The following is a description of a gene set: Genes up-regulated in H1299 cells (lung cancer) by expression of SMARCA4 off a plasmid vector. studied in species Homo sapiens from publication Medina PP, Carretero J, Ballestar E, Angulo B, Lopez-Rios F, Esteller M, Sanchez-Cespedes M (PMID 15731117) Human Gene Set: MEDINA_SMARCA4_TARGETS BRG1, also called SMARCA4, is the catalytic subunit of the SWI/SNF chromatin-remodelling complex and influences transcriptional regulation by disrupting histone-DNA contacts in an ATP-dependent manner. BRG1 and other members of the SWI/SNF complex become inactivated in tumours, implying a role in cancer development. To understand the contribution of BRG1 to lung tumourigenesis, we restored BRG1 in H1299 lung cancer cells and used cDNA microarray analysis to identify changes in gene expression. Forty-three transcripts became activated, whereas two were repressed. Chromatin immunoprecipitation of resulting candidate genes revealed that the CYP3A4 and ZNF185 promoters recruited BRG1 and that recruitment to the CYP3A4 promoter was specific to this gene and did not involve the CYP3A5 or CYP3A7 family members. Moreover, specifically BRG1 but not its homologue BRM was recruited to the CYP3A4 and ZNF185 promoters. To explore their potential relevance in lung tumours, levels of CYP3A4 and ZNF185 transcripts were evaluated in seven additional lung cancer cell lines. CYP3A4 was undetectable in any of the lung cancer cells tested, and only the CYP3A5 family member was present in the A549 and Calu-3 cells. In contrast, the amount of ZNF185 transcript clearly varied among lung cancer cell lines and severely reduced levels were observed in BRG1-deficient cells, except those of A427. We extended these observations to 27 lung primary tumours using real-time RT-PCR (TaqMan) and observed that four (15%) and 14 (52%) of them had BRG1 and ZNF185 downregulation, respectively, when compared with normal lung. No significant correlation between reduced levels of BRG1 and ZNF185 was observed, indicating that additional mechanisms to BRG1 inactivation may contribute to the loss of ZNF185 expression in lung tumours. In conclusion, our results provide evidence that transcriptional activation of ZNF185 and CYP3A4 is mediated by direct association of BRG1 with their promoters and also indicate that a decreased level of ZNF185 is a common feature of lung tumours and may be of biological relevance in lung carcinogenesis., and this is the list of marker genes: CDKN2D, DYNC1H1, NADSYN1, CEBPB, KIFBP, TBX2, CDH11, RBM4, MXD4, PCDH1, CYP3A4, CLPX, HDAC4, CCDC85B, SMAD6, C19orf12, RALBP1, ASCC1, PGM2L1 (NCBI Gene Id 283209), SKAP2, TNFSF10, CTSS, RASSF1, ATP6V1B1, SNAPC2, SLC2A4 (solute carrier family 2 member 4), TNFSF13, CDH16, SMARCA2, SMARCA4, ST6GALNAC4, ECM2, STARD10, CSNK1G2, NFKB2, LDB1